The following is a description of a gene set: Mouse Gene Set: GRAESSMANN_RESPONSE_TO_MC_AND_SERUM_DEPRIVATION_DN from publication Graessmann M, Berg B, Fuchs B, Klein A, Graessmann A (PMID 17160024) Genes down-regulated in ME-A cells (breast cancer, sensitive to apoptotic stimuli) upon serum deprivation for 22 hr in the presence of medium concentrate (MC) from ME-C cells (breast cancer, resistant to apoptotic stimuli). species: Mus musculus Impairment of the complex regulatory network of cell death and survival is frequently the reason for therapy resistance of breast cancer cells and a major cause of tumor progression. We established two independent cell lines from a fast growing mouse breast tumor (WAP-SVT/t transgenic animal). Cells from one line (ME-A cells) are sensitive to apoptotic stimuli such as growth factor depletion or treatment with antitumor agents (e.g. doxorubicin). Cells from the second line (ME-C cells), which carry a missense mutation at the p53 codon 242, are very insensitive to apoptotic stimuli. Co-cultivation experiments revealed that the ME-C cells mediate cell death resistance to the ME-A cells. Microarray and Western blot analysis showed that osteopontin (OPN) is selectively overexpressed by the ME-C cells. This glycoprotein is the most abundant protein secreted by the ME-C cells and we obtained strong indications that OPN is the main antiapoptotic factor. However, the OPN containing ME-C cell medium does not alter the expression level of pro- or antiapoptotic genes or known inhibitors of apoptosis (IAPs). Its signaling involves mitogen-activated protein kinase (MAPK)/extracellular signal-regulated kinase (ERK) kinase (MEK)1/2 as the kinase inhibitor PD98059 restores apoptosis but not the Akt inhibitor. In the ME-A cells, mitochondrial cytochrome c release occurs with and without external apoptotic stimuli. OPN containing ME-C cell medium does not prevent the mitochondrial cytochrome c release and caspase-9 processing. In serum starved ME-A cells, the OPN containing ME-C cell medium prevents caspase-3 activation. However, in doxorubicin-treated cells, although apoptosis is blocked, it does not inhibit caspase-3. This indicates that the ME-A cells distinguish between the initial apoptotic stimuli and that the cells possess a further uncharacterized control element acting downstream from caspase-3., and this is the list of marker genes: Lpin1, Mphosph6, Dnm1, Pigu, Pkp2, Porcn, Tspan33, Rapgef3, Serpinb1a, Galk1, Mt2, Odf2, Pkp1, Cndp2, Usp17la (NCBI Gene Id 13531), Vegfa, Phex, Bcl2l2, Zfp706, Tnnt2, Lhpp, Il15ra, Gbe1, Pvr, Ppfia4 (protein tyrosine phosphatase, receptor type, f polypeptide (PTPRF), interacting protein (liprin), alpha 4), Il24, Polr3k, Mknk1, Higd1a, Insrr (insulin receptor-related receptor), Thsd1, Emc4, Kdelr3, Paxip1, Man2b2, Plagl2, Csdc2, Gp1bb, Serpine1, Dll4, Epb41l4b, Slc66a2, Septin5, Tpd52, Tes, Car9, Nisch, Krtap19-1 (keratin associated protein 19-1), Rem2, Med24, Krt14, Gcnt2, Alx3, Hid1, Gys1, Copb2, As3mt, Txndc11 (thioredoxin domain containing 11), Nasp, Pdlim7, Rab2a, Cdc37, Tmem191, Homer1, Klk1b22, Slc25a29, Crb3, Eno2, Cldn9, Abcd4, Cdr2, Klk9, Atxn7, Kif2a, Efhd2, Wap, Prkca, Casp6, Cldn3, Slc25a14, Ramp3, Ero1a, Gpr35, Tpm3, Ubxn2a, Dnajb6, Naaa